Given this list of marker genes BBS7, SLC16A7, ZNF804A, DOCK8, AP1B1, KCNV1, PCDH20, ANKRD34C, NCOA4, CACNB4, TFEC, STAG2, SH3BGRL2 (SH3 domain binding glutamate rich protein like 2), ANXA1, DPYD, KCNA2, SCAI, SBNO1, PPDPFL, CYP4F11, FAM169A, KDM7A, ACBD3, HBP1, ANLN, CXCL12, TM9SF2, ARID4B, PCGF5, RERE, TASOR, INO80D, CHM, TNFRSF11B, RUFY2, SNAP91, MYF5, SCML1, SRGN, IL15RA (NCBI Gene Id 3601), AFF1, NET1, SLFN12, BHLHE22, AEBP2, BLZF1, RASGEF1A, SCN9A, TGFBR3, SNTB1, RPS6KA6, ARHGAP39, FGF5, SYDE2, SEMA3D (semaphorin 3D), VIP (NCBI Gene Id 7432), CTDSPL2, YAP1, RPRD1B, RSBN1L, KDM4C, SGK3, NUMB, SYT14, BTRC, IRX2, FOXN2, DNAJB14, TMEM182, SCML2, POMP, ZER1, ATP8B2, FRMD3, RABGAP1L, FBXO4, ARL5B, NIP7, SAMSN1, MBNL3, TAF4, EPHA8, MAB21L1, EDDM3A, SYNPO2, NCK2, GIN1, ATF1, VGLL3, RNF217, MTF2, PAK1IP1, TMTC4, ARHGAP21, EIF5A2, LRP6, TPK1, TAT, ZCRB1, IL22RA2, CRB3, TUT4 (NCBI Gene Id 23318), FOXJ3, COG6, PCMTD1, TNRC6C, FLVCR1, CCL11, ELAVL1, DBT, ZFP14, ABCA5, DUSP8, STK26, NECTIN3, PCDH11Y, COBLL1, A1CF, CPED1 (cadherin like and PC-esterase domain containing 1), FKBP5, ZNF292, C21orf91, LDLRAD4, MSI2, DLG3, TTC28, TRPM7, CBX8, DDX52, CSNK2A2, HACE1, BVES, SSTR1, RBM47, GLRB, RORA, BRD10, KIF13A, KLHL29, ZDHHC2, FGF18, SPRY2, AIMP1, CAMTA1, LSM12, MID2, CBX3, CALHM2, SMAD7, RRM2B, CHL1, C1QTNF3, ASB14, ERI2, POLR2M, PLEKHA5, PDZRN4, STS, PPP1R15B, TOX4, ZNRF3, SNRPF, GABRG1, OLIG3, FOXA2, CPSF6, UBA6, CLTRN, FZD5, NR4A1, SLC25A3, SLC38A2, KIF21A, ZNF362, AMOTL2, PCDH19, SELE, MCTS1, PTPRE, HHIP, SLC2A1, PRIMA1, SNX16, CLOCK, TBX5, FAM135B (NCBI Gene Id 51059), RHOT1, FAM72A, TNFSF9, DIP2C, MEX3C (mex-3 RNA binding family member C), NEK1, NLK, WNT3, ARFGEF1, CDYL2, CLDN14, ABL2, WIPF1, MFAP5 (NCBI Gene Id 8076), GRXCR1, MYADM, UBE2W, PTEN, LRP8, CDS2, HTR2A, TEX2, SMARCA1, HOXA9, RDX, MTX3, RER1, ECE1, TOB1, ARL5A, SNAI1, PHC3, MARCHF6, ZZZ3, WASL, KHSRP, LIN7A, WASF1, TMTC2, OSBP, LYAR, PLN, NEGR1, UBE2H, AAK1, ABCA9, SDC4, ZNF275, THAP9, LRRC58, NKTR, CNIH4 (NCBI Gene Id 29097), PCDHA2, VASP, IPCEF1, RGCC, PRKAA1, PIK3C2A, ZDHHC5, CEP192, ZNF470, HLF, SLC17A6, BLTP2, NDFIP2, ZFHX3, BET1, LHX1, RASSF6, SLC26A7, PTER, NAA25, CNOT7, DISC1, SMAD6, IL6ST, KAT2B, PRKCD, GSTCD, FAM135A, AFF4, ID1, ADCYAP1, P2RY1, ADGRB3, ZNF516, TMX3, RPS6KB1, CEP104 (centrosomal protein 104), HMCN1, SUCNR1, SERINC3, BCL11B, PRDM1, SATB2, PPP4R4, KCNN3, PLSCR4, PRR16, DUSP16 (NCBI Gene Id 80824), PHIP, F2R, ZNF260, ASF1B, SLC4A4, EEIG2, MXRA5 (matrix remodeling associated 5), GPR88, PREX2, KPNA6, PLEKHA8, KIF14, RARB, BDNF, ZNF214, DOK6, DNAJC6 (DnaJ heat shock protein family (Hsp40) member C6), ZEB2, ARL8A, ACTR3, KCNH3, CCND2, STEAP2, MPP7, DIAPH3, NCOA1, DRD1, DLG2, CCSER2, MTR, PLXNA2, BBX, LRRC31, PPP6R1, CCNH, RAP1A, MOSMO (modulator of smoothened), ZC3H12C (zinc finger CCCH-type containing 12C), GTPBP10, KAT6A, FUT9, PLXND1, NFIB, ATOSA, PTPN4 (protein tyrosine phosphatase non-receptor type 4), ZBTB11, CFHR3, HBEGF, TAP2, ALG6, DAZAP2 (DAZ associated protein 2), FABP2, STAM2, PLAGL1, PACSIN2, DLG1, PDE9A, NEUROD1, EFR3A, KDSR, IGFBP7, MIGA1 (mitoguardin 1), ARSK (NCBI Gene Id 153642), PPIP5K1, NUP54, CELF4, MMP13, RAB38, TAF1A, KLF6, INTS6, LYSMD2, ATF7IP, CPEB2, NR3C1, OPN3, DCLK1, PTPN13, BLOC1S6, ERMN, MGA, RAD51B, PPM1A, PRPF18, NTN1, ZBTB20, MYOZ2 (NCBI Gene Id 53348), MAP3K8, PRRX1, USP46, MERTK, MITF, PIKFYVE, SPDYE3, GOLM1, KIF18A, QKI, PEG3, DCAF8, PTAR1, PCID2, TCEAL1, BAMBI, GSKIP, PCSK5, BMP4, ACSL6, EDNRB, VEGFA, MEF2A, SLC6A15, DMRT2, ALKAL1, GJA9, CDC42EP3, TMED4, LRP2, SP1, GABRG2, POU4F2, RECK, SLIT3, HAPLN1, GABRA4, GRAMD1B, PPP1R2 (NCBI Gene Id 5504), PRPF40A, MEOX2, NEDD4L, HSF2, EREG, KREMEN1, TBX4, KLHL14, WIF1, GUCY1A2, ALG10, IDS, B4GALT6, SLC2A13, UTRN (utrophin), TEC, MOSPD1, SLC5A7, EPHA4, DGKH, TXNIP, ESRP1, MARCHF3, ZNF367, NF1, LAMA4, IFNE, GCLM, SKIL, SPDYE5, LTN1, SLIT2, SPRY3, CSF2, TAOK1, CNTNAP1, FGFR2, CXCL5, MRTFB, SP4, FMNL2, GRPEL2, HOMER1, RIMKLB, SNX14, CD2AP, STRN, COL4A1, ZNF614, TM9SF3, PCBD2, SUCLG2, SLC30A7, ACKR3, ATP4B, ADAMTS5, ARID2, ZFP36, ITIH2, LRRC4, KIAA0319, SPRY1, GDAP2, PDIK1L, FAM199X, ACVR2B, ZC2HC1A, USH2A, MEX3B, ENPP4, GABPA, NEDD1, WDR17, TMEM108, ACVR1, FGFR1, MMD, SPRED1, ASF1A, DCP1B, KDM6A, ITPRID2, GEM, EPHA7, TTC33, WSB1, ALCAM, ZFP36L2, C16orf87, SLC25A42, CAST, DNAJB4, DAPK1 (death associated protein kinase 1), TET2, SLC7A11, F11, TMEM135, RANBP10, NSD2 (NCBI Gene Id 7468), SETDB2, USP43, RIF1, FKBP1A, PIGK, RAB11FIP2 (RAB11 family interacting protein 2), OSBPL3, DMXL1, KCNJ2, INSYN1, UBXN2A, PHLPP1 (NCBI Gene Id 23239), FEM1C, SS18L1, SHH, SYT1, HERC1, FSD1L, RICTOR (NCBI Gene Id 253260), SPDYE1, SLC25A40, RAPGEF6, CPEB3, PRDM12, EPHA2, GAPVD1, VSTM2A, SPDYE6 (speedy/RINGO cell cycle regulator family member E6), CEP120, CDK6, PLXDC2, TMEM161B, DSCAM, NECAB1, FBXO43, CLVS2, LYSMD3, ZNF518A, RIT1, VAMP2, ZFP36L1, DACH1, FAM72C, TRPS1, DOCK7, WIPI1, RASEF (RAS and EF-hand domain containing), CSMD3, ADAMTSL3, DUSP1, BMP2, TMEM196, TUSC1, NUP98, PHACTR2, PPFIBP1, STK39, ZNF507, NEXMIF, NCKAP5, METTL6, LBR, DSCAML1, NUFIP2, SEC11C, KCNH5, RGMB, TIAM2, CDC6, ANXA5, KLF3, MYT1, TRAM1, SPSB1, NMT1, VPS13C, CENPK, NPTN, KRR1, ST6GALNAC3, ABHD10, EDIL3, COPA, PLEKHF2, CALCOCO1, CREBZF, COL11A1, ADAMTS9, ARHGAP20, CCND1, ZNF566, TC2N, BOC, NECAP1, CBX4, NAPG, SLC18A2, ETS1, POU2F1, SBDS, ALKBH5, ANAPC7, SLCO4A1, EPHA1, CFAP20, ATXN7L2, CHD9, CHIC1, PHAX, SRSF9, VPS36, LRIT2, SNTG1, PUM2, GTF2A1, FOXD3, RGS20, CUL3, CXXC5, CA2, L3MBTL4, HP1BP3, ALX4, GSE1, RSF1, PTPN20 (NCBI Gene Id 653129), DZIP1L, PARVA (parvin alpha), TFAP2B, CHRNA9, BRF2, CARMIL1, VASN, CORIN, GPR22, UIMC1, CNPY2, MEI4, UBE4B, NEK3, ABHD17B, AMOT, SPATA18, BRINP3, GID8 (GID complex subunit 8 homolog), GSR, ZNF827, ARK2N, CNTN6, KIF27, FBXO42, CHMP1B, DENND4A, LRRTM3, AFF3, ZNRF1, C9orf72, ROCK2, PLAG1, LIFR, NR4A3, SEPTIN7, NEMF, LRRIQ3, RFX3, HECTD2, ASXL3, ANTXR2, AP1AR, RANBP3L, TENT5A, TRPM6, HDAC9, PCDH10, EMILIN2, EFNB2, KCNQ3, FAM72B, FOSB, RC3H2, NPTX2, ARAF, PRDM11, LARP4, SH3RF1, ZDBF2, CALHM5, CSGALNACT2, BRD4, SWT1, LDLR, SUSD6, ANAPC10, MEF2D, GPR158 (G protein-coupled receptor 158), CLDN11, TSEN34, CSN2 (NCBI Gene Id 1447), IMPA1, WDR44, ZBTB44, SNX1 (NCBI Gene Id 6642), SPOCK3 (NCBI Gene Id 50859), CADM4, THSD7A, GCFC2 (NCBI Gene Id 6936), DEPDC1B, CLINT1, ESYT2, USP15, TRPC1, ADGRA2, SMPX, ZIC5, GOPC, EVI5, WDHD1, ITGB8, CDR2, MICB, CNTNAP4, DLL1, NEXN, CLCA2, ARHGEF38, PELI1, SCCPDH, FAN1, GPM6A, ZNF280B, PRRC1, PRKG2, MOB1B, ZBTB10, PKN2, GOLIM4, ARHGAP6, SLC9A2, BHLHE40, FZD3, TCF21, COL27A1, CRTC2, FBN2, MMUT, DNAJC21, GTPBP2, STARD13, PIK3C2G, ABCC1, CXADR, ADAMTS3, TENT4B, PHTF2, REPS2 (NCBI Gene Id 9185), OLFML2B, ATAD5 (ATPase family AAA domain containing 5), SLC45A4, RIN2, FAM72D, SIK3, DSG4, EP300 (E1A binding protein p300), ELMO2, SERPINE1, SYP, ARID5B, SMC2, EFNA2, ST8SIA4, FAM241A, TMTC1, RXFP1 (relaxin family peptide receptor 1), BTAF1, TLE4, SPRYD7, STXBP5, SV2C, SVIL, TMC7, ZSWIM6, SLC25A24, CREBBP, GCOM1, TRIM33, PSMD14, FAM13C, GRIA2, ARHGAP5 (NCBI Gene Id 394), BTG2 (NCBI Gene Id 7832), PGR, CXCL14, FNDC3B, WDFY3, NRIP1, SAMD8, ARHGEF1, XRCC5, CCDC91, CEP135, CD38, RBM41, SOX9, EXOSC8, PWWP3B, PDE5A, PILRA, FGD4, SAV1, F3, TACC1, MSRB3, CREB1, EXOC8, PPIP5K2, SGPP1, SANBR, KIF23 (NCBI Gene Id 981), ZNF81, MIPOL1, PHF8, SMIM10L1, KIF20B, KCNAB1, PKHD1, TMEM39A, ABCB5, PEX2, EPS15 (NCBI Gene Id 2060), HOXA11, RASSF8, GPR82, RC3H1, PCDH7, CAMK2D, CYP1B1, SMU1, YIPF4, FBXL16, TAFA4, ZBTB1, OR2L13, PRKCI, ZNF521, NOX3, TCF4, KIRREL1, TMEM106B, CD36 (CD36 molecule (CD36 blood group)), SF1 (splicing factor 1), SCPEP1, DPYSL2, FKBP14, TGIF1, NHLH2, ANKS1B, ELK3, NR2C1, PSMD11, CCL2, TBL1XR1, NTF3, KL, C15orf61, CHCHD3 (coiled-coil-helix-coiled-coil-helix domain containing 3), C18orf63, ADPGK, ALG2, SLITRK4, RB1CC1, TMF1, SPART, IQCK, VPS37A, PCSK6, MEX3D, HESX1 (NCBI Gene Id 8820), SERPINB8, TASP1, PURA, CASKIN1, TMTC3, SLC4A10, SVIP, C1orf174, ERCC4, CDON, MINDY3, PCDH11X, TRAF6, here is a description of the gene set: from publication Chen Y, Wang X (PMID 31504780) Human Gene Set: MIR1277_5P studied in species Homo sapiens Genes predicted to be targets of miRBase v22 microRNA hsa-miR-1277-5p in miRDB v6.0 with MirTarget v4 prediction scores > 80 (high confidence targets).